The following is a description of a gene set: from publication Chen Y, Wang X (PMID 31504780) Genes predicted to be targets of miRBase v22 microRNA hsa-miR-6773-5p in miRDB v6.0 with MirTarget v4 prediction scores > 80 (high confidence targets). studied in species Homo sapiens Human Gene Set: MIR6773_5P, and this is the list of marker genes: CHTF8, ST3GAL3, NMT1, SLC7A6, BOK, GABBR2, TSLP, HOXB5, GNG12, ELOVL5 (NCBI Gene Id 60481), CD44, LINC02953, RNF26, PAG1, CYP1B1, CAPNS1, AMMECR1L, B3GNT3, RSF1, GPR88, FAM83A, ZNF93, SNX21, ITGB4, P2RY8, SIRPA, SLC25A42 (solute carrier family 25 member 42), SUMF2, AOC3, GAREM1, SLC41A1, USP12, UBE2J1, RBMXL3, GUCD1, SLC2A1, SEMA4F